Given this list of marker genes Stat1, Ppp4r2, Tor3a, Mgat2 (mannoside acetylglucosaminyltransferase 2), Dcaf12, Slc16a6, Garre1, Ptk2b, Polr2d, Nars1, Rest, Hipk3, Abtb2, Sgta, Atp6v0a1, Pstpip1, Calm2, Tomm22, Ranbp2, Wdr1, Egln2, 5031439G07Rik, Dido1, Ptpn1, Ier5, Acbd6, Acsl5, Crtc2 (CREB regulated transcription coactivator 2), Glg1, Suds3, Sumo1, Adam17, Ptafr, Dusp2, Ccdc71, Tbc1d10a, Pik3c2a, here is a description of the gene set: from publication Tabula Muris Consortium (PMID 32669714) Mouse Gene Set: TABULA_MURIS_SENIS_TRACHEA_GRANULOCYTE_AGEING species: Mus musculus